Given this list of marker genes Kcnk3, Smad3, Kcna5, Ryr3, Drd3, Ryr2, Hrc, Got1 (NCBI Gene Id 14718), Epo, Slc8a1, Atp2b1, Oprm1, Tmbim6, Gtf2i, Smpd3, Il6st, Drd2, Bcl2, Lrp1, Nos1, Npy1r, Atp1a2, Mtnr1b, Nol3, here is a description of the gene set: Mouse Gene Set: GOBP_NEGATIVE_REGULATION_OF_CYTOSOLIC_CALCIUM_ION_CONCENTRATION Any process that decreases the concentration of calcium ions in the cytosol. species: Mus musculus